The following is a description of a gene set: Enables the transfer of carnitine across a membrane. Carnitine is a compound that participates in the transfer of acyl groups across the inner mitochondrial membrane. Mouse Gene Set: GOMF_CARNITINE_TRANSMEMBRANE_TRANSPORTER_ACTIVITY species: Mus musculus, and this is the list of marker genes: Slc22a5, Slc25a20, Slc6a14, Slc22a4, Slc22a16, Slc16a9, Slc22a21, Slc22a1